Given this list of marker genes Unc13b, Syt4, Rab3a, P2rx7, Baiap3, here is a description of the gene set: Any process that modulates the frequency, rate or extent of dense core granule exocytosis. Mouse Gene Set: GOBP_REGULATION_OF_DENSE_CORE_GRANULE_EXOCYTOSIS species: Mus musculus